The following is a description of a gene set: Human Gene Set: ACAWYAAAG_UNKNOWN Genes having at least one occurrence of the highly conserved motif M142 ACAWYAAAG in the regions spanning 4 kb centered on their transcription starting sites. The motif does not match any known transcription factor binding site. Comprehensive identification of all functional elements encoded in the human genome is a fundamental need in biomedical research. Here, we present a comparative analysis of the human, mouse, rat and dog genomes to create a systematic catalogue of common regulatory motifs in promoters and 3' untranslated regions (3' UTRs). The promoter analysis yields 174 candidate motifs, including most previously known transcription-factor binding sites and 105 new motifs. The 3'-UTR analysis yields 106 motifs likely to be involved in post-transcriptional regulation. Nearly one-half are associated with microRNAs (miRNAs), leading to the discovery of many new miRNA genes and their likely target genes. Our results suggest that previous estimates of the number of human miRNA genes were low, and that miRNAs regulate at least 20% of human genes. The overall results provide a systematic view of gene regulation in the human, which will be refined as additional mammalian genomes become available. from publication Xie X, Lu J, Kulbokas EJ, Golub TR, Mootha V, Lindblad-Toh K, Lander ES, Kellis M (PMID 15735639) studied in species Homo sapiens, and this is the list of marker genes: LIME1, OTP, SKIDA1, TIGD2 (tigger transposable element derived 2), LIX1, AP5M1, ROBO1, SIX5, DKK1, NUMB, SHOX2, KCNQ1DN (NCBI Gene Id 55539), CUTA, REV1, RNF122, HSD11B1, NHLH2, CASK, HOXC11, PAQR9, GRIK3, TMEM126B, HOXD12, GABRB2, DOCK4, PTK7, SLC27A4, LRCH2, PRDM13, TMSB4XP1, DCX, GAD1, RTRAF, NOL4, HNRNPA0, RYBP, TRPC4AP, ABR (ABR activator of RhoGEF and GTPase), MYH10, ARHGAP20, TMSB4XP6, RAB3C, ZNF277, ZBTB40, CLASP1, GPC4, EXOC5, CLC, HAND1, SPAG9, EPHB3, NARF (nuclear prelamin A recognition factor), EYA3, TMSB4XP4, TMSB4XP8, LRRTM4, SAAL1, RPRD2, PCDH8, DOCK11, PAM, CHMP2B (NCBI Gene Id 7877), TMSB4X, CHN2, ASCL4, KCNE1, LCOR, CSRNP3, GPHB5, LHX9, HOXB7, EML4, GSC, RAG2, PREX2, TLNRD1, H2AX, SNCG, SMARCC1, FGF20, TBPL1, ATAT1, ANKH, OTX2, HSD3B7, AKIRIN2, JADE1, HEY1, MMRN2, PDGFA, ELAVL4, ZC3H6, REM2, LIX1L, CDX1, FN1 (fibronectin 1), TENT4B, PARD6A, DDX6, ALDH1A2, RNF44, GABARAP, PBX1, OAZ2, S100A3, SIRT6, SCP2D1